Given this list of marker genes CNST, IRX3, DUSP5, PERP, ZNF737, LPIN1, FAM221A, FAM3C, USP13, CELSR1, GALNT11 (NCBI Gene Id 63917), CIART, RUFY1, TANC2 (NCBI Gene Id 80259), HCLS1, PDPN, SLC43A3, SERINC2, TMEM117, LINC01117, LGALS7B, TMEM140, HGF, OSBPL1A, TNFRSF4, GBE1, WSB2, TOP2A, ADK, ATP11C, HEPH, TMEM45A, CALHM2, ADAM22, TBXA2R, AGA, LRRC70, KIF21A, SYS1, COQ8A, KIF16B, SOCS2, SEC14L2, SGIP1, APOE, PLOD2, HYAL3, GRAMD4, TRMT9B, KBTBD11, SETD9, RGL1, MFAP4, TMTC1, CCDC3, HES4, C16orf87, HSDL2, ETV2, PLPP5, KCNQ1OT1, FAM131A, NTN1, TEX2, PPARG, REEP1, OTULINL, VANGL1, TPCN1, KLHL4, TMEFF1, AOPEP, CYB561D2, CLIP3, MITF, PWWP2B, SRGAP3, IRF2BPL, WDSUB1, BIK, AKR1C3, ZNF480, BCR, TTN, NRGN, HLA-F (NCBI Gene Id 3134), CCDC126, RCBTB1 (NCBI Gene Id 55213), S100P, CARS1, NBL1, OAF, LINC01116, SPOCK3, ZIC2, MRGPRF, FILIP1L, ASPH, LTBP1 (latent transforming growth factor beta binding protein 1), ITGB8, COMMD3 (COMM domain containing 3), NMD3, DLG1, FAM117A, GLIDR (glioblastoma down-regulated RNA), FLRT2, LRRN2, STRADA, DKK3, EBLN3P, SLC22A23, C20orf204, NPC1 (NCBI Gene Id 4864), LRRN4CL, GLS, PLAC9, B3GNT8, PLPP1, CPE, GJD3, MMP16, HACD2, PCLO, COL4A5, MRAS, TNFAIP8L3, MSMP, CHRDL1, GALC, NFATC2, RUVBL1, GUCY1A1, TSHZ1, MIRLET7BHG, EBF1, TULP4, PPP1R9A, TMTC4, MICU3, MET, RCAN1, PAK3, PAIP2B, STARD9, SOCS6, TRDC, PTPRS, SBSPON, F8, ZDHHC24, ZNF195, CAMK1, OSTM1, ORAI3, LDOC1, LRRC61, CTTNBP2, CFI, GLIS3, ICE2, GAB1, MTFMT, SLC12A7, C15orf61, POLB, FOXO1, C12orf75, NLRC5, CCDC141, CCL21, ZNF568, KLHL23 (NCBI Gene Id 151230), GALNS, FHIT, PTPN3, ZNF385A, FZD6, KLF12, HSD3B7, DBNDD1, CEP15 (centrosomal protein 15), DPP7 (NCBI Gene Id 29952), AMN1, DPP4, EXOSC7, SYNPO, ADAMTS12, SLC38A1, MAPRE3, LYRM1, ANGPTL2, LETR1, ALDH1A2, HOXB4, MEST, ARID5B, PTPN14, NPY1R, FILIP1, TFF3, ANKRD6, PGM5, DDX3Y, TMC6, MAGED4B, PTPRE, ACAD10, AKR1C1, HOXD8, SYNE1 (spectrin repeat containing nuclear envelope protein 1), CPT1A, RASAL3 (RAS protein activator like 3), PARD6G, RNASE4, NLGN4Y, C14orf132, TPD52, RIOX1, ACAP3, LGALS3, COL9A3, UCHL1, EML3, SULF2, ITGA9, PLXNB1, DTX1, SIAE (sialic acid acetylesterase), TMEM102, IER3, GRAMD2B, FAHD2B (fumarylacetoacetate hydrolase domain containing 2B), ADAM9, TBC1D9, SCG3, RTTN, IFT57, C1QTNF2, PTPRF, NBAS, DTX3, PCAT6 (NCBI Gene Id 100506696), STRN, CCDC80, SERINC5, ADIRF, TBC1D8, LINC00636, SLC48A1, CTXN1, RPRD1A, SCPEP1, NFATC1, SQOR, DDX10, FGR, FHDC1, KHDRBS3, ARHGAP42, PRICKLE1, PWP2, SEMA3D, LY6L, GALNT2, LYSMD2, NEO1, B9D1 (B9 domain containing 1), SLC5A3, RAI2, TTC8, B3GALT4, FAM110B, SYNM, KANK2, NDUFAF5 (NADH:ubiquinone oxidoreductase complex assembly factor 5), TMEM38B, PLBD2, HVCN1, IDE, FZD10, NAV2, ZC3H8, FOXC2, EDNRB, PCCA, COL5A2, SUN2, PHLDB3, COQ10A, DOC2B, PIK3C2G, TARS3, CRNDE, CEACAM1, HOXD-AS2, ENOX1, PBXIP1, PDGFD, ST6GALNAC3 (NCBI Gene Id 256435), COQ2, THBS3, DYNC2LI1, SPIN4, AHI1, PIP5K1C, CXXC5, BSCL2, NAPG, GREB1, PTPRK, OXCT1 (NCBI Gene Id 7898), ENTREP1 (endosomal transmembrane epsin interactor 1), SEMA3A, PITPNM1, SLC38A4, URI1, CCDC102B, SPATA6L, ADAMTS6, PELI2, TM7SF2, ZNF680, FOXP2, MIF4GD, TPD52L1, LYPD6, FAM98A, LY96, L3MBTL3, SLPI, BCL7A, ARID5A, TNFAIP2, MYO5C, FBXO17, PPFIA3, RANBP9, CRIP1, UNC5B, KDELR3, CYP27A1, NIT2, LAMA5, H4C12, MBP, ZMYND8, RINL, ZDHHC1, HSBP1L1, HS6ST1 (heparan sulfate 6-O-sulfotransferase 1), IL1R1, COLEC12, ENTPD6, MAPK7, FBXO44, B3GNT5, PRKCZ, MCUB, GAA, PPL, COG6, VKORC1L1, KIZ, ABHD2, PLCD1, MIR99AHG, MVP, RHPN1 (rhophilin Rho GTPase binding protein 1), AGAP2-AS1, F8A3, TFEB, TMEM33, CLDN11, GPAT2, PDE1A, ADAM19, BBIP1, STARD10, MAGED4, HOXA7, PSEN2, ITGAV, BHMT2, UNC119, TRIM47, RAB11FIP1 (NCBI Gene Id 80223), DUSP2, TUBB2B, DAPK1, LMBR1L, MOB3B, ANK2, APBA2, BAMBI, PDLIM1 (PDZ and LIM domain 1), ADA2, TRIP6, PODXL2 (podocalyxin like 2), ARL15, LACTB2, BMX, ABCA4, DNASE2, FBXO34, AKR1C2, PEG10, SLC16A7, VPS39, ANO10, C1orf198, PLSCR3, PIGP, ACYP2, RASSF4, FLNC, TPBG (NCBI Gene Id 7162), NINL, TMEM120A, AK4, NALCN, NR1H3, RAPGEF4, DSEL, STPG1, PRKAA2, PTGR3, EDDM13, GNB5, ATP10D, MZF1, MIGA1, IGSF3, SRD5A3, IFT122, MAPK13, BRSK1, SV2C, OLFML1, DIXDC1, NBEAL2, SCARA3, ABCA3, GSPT2, RASGRP2, ITPR1, TCTN3, NICOL1, RADIL, SWAP70, ST7, BCHE, SLC44A3, DNAJC16, S100A4, CLASP2, APTR, RASD1, ARHGAP10, MPP7, IGHMBP2, PRKAG2, MBOAT1, SLC2A6, HS3ST1, SLC6A6, RAB6B, PAQR8, FAM222B, GDF10, LTBP4, SLC37A1, LAPTM4B, LINC00513, P2RX4, NPPC, EPS8L1, SLC41A1 (NCBI Gene Id 254428), ANGPT2, ANKH, POF1B, DOP1B, UBE2E2, DBNDD2, EPB41L3, ALDH3A2, NTS, GSTM3, MYEF2, ZNF211, FLRT3, SGK3, ALPK3, PRXL2C, SRPK1, PARD3 (NCBI Gene Id 56288), LYPD3 (LY6/PLAUR domain containing 3), PGAP4, CABIN1, GLRX, SPPL2B, TSHZ2, PLEKHA4, BEND5, NUPR1 (NCBI Gene Id 26471), ITGB4, PORCN (porcupine O-acyltransferase), IGSF8, ZSCAN2, PHETA2, GCNT2, SPR, GPRC5D-AS1, ABCC10, RHOBTB1, PROX1, BHMT, TXNRD2, SEMA4D, ACKR2, RASSF8, NFX1, NMNAT2, NLGN4X, GPER1, PDLIM3, LGALS7, CAMK2D, CASK, A4GALT, NHERF1, PDE4D, PDGFA, SESTD1, IFI6, MID1, R3HDM2, RHBDD3 (NCBI Gene Id 25807), TBX1, SLC35A5, ZDHHC17, HOXD9, TUBB3 (tubulin beta 3 class III), AGAP1, HAGLROS, CDC42EP5, TMOD2, SDC4, FKBP1B, ZSCAN16, DBR1, PPP3CC, C17orf58, KCNN3 (NCBI Gene Id 95947), JARID2, HOXD3, MXRA8, ZNF107, NEXN, MGST1, H4C11, GALNT1, TNFRSF11A, CBFA2T3, CCNJ, PKHD1L1, RABGAP1, CLIC2, POC5, SPIN2B, SNX25, HSPA2, SGCE, NR2F1-AS1, RAB3IL1, SCN3A, CROT, EIF4EBP3, ASGR1, FAM171B, CRAT, CASP6, LRP11, IDS, ADNP2, CEP85L, MARK1, CYP39A1, SLC35B4, PDE6G, SLC7A1, ZNF790 (zinc finger protein 790), ANPEP, MEDAG, NOL3, PDE7B, UNC93B1, TBC1D4, MLYCD, PDLIM4, SFXN3, SDC3, NAAA, C2CD4C, IGF1, here is a description of the gene set: SCG3+ lymphatic endothelial Human Gene Set: HE_LIM_SUN_FETAL_LUNG_C3_SCG3_POS_LYMPHATIC_ENDOTHELIAL_CELL from publication He P, Lim K, Sun D, Pett JP, Jeng Q, Polanski K, Dong Z, Bolt L, Richardson L, Mamanova L, Dabrowska M, Wilbrey-Clark A, Madissoon E, Tuong ZK, Dann E, Suo C, Goh I, Yoshida M, Nikolić MZ, Janes SM, He X, Barker RA, Teichmann SA, Marioni JC, Meyer KB, Rawlins EL (PMID 36493756) studied in species Homo sapiens